Given this list of marker genes MAGT1, MIR29B1, SCN7A, ATP5MF (ATP synthase membrane subunit f), CATSPER4, PKD2, SPHK2, KCNH4, SLC39A8, FXYD5, PLCE1, PML, DIAPH1, CX3CL1, NDUFB10, ATP6V0E2, ASIC1, TMSB4X, KCNA7 (NCBI Gene Id 3743), TMEM63A, NDUFA7, FXYD3, GRINA, ATP5MGL, KCNG1, ATP13A4, CACNA1H, AKAP6, KCNJ4, WNK2, ATP4A, SLC25A14, UNC80, CALM2, CTNS (cystinosin, lysosomal cystine transporter), ATP1B1, PKD1L1, REM1, LETM1, ATP6V0C (NCBI Gene Id 527), ANO1, CXCR3, SLC17A8, SLC12A8, SLC25A25, MIR208B, TRPV4, CALCA, GSTO1, MT-ND5, SLC1A3, SLC5A2 (solute carrier family 5 member 2), LCN2, KCNJ3, NDUFB9, KCNMB1, NALF1, KCNH8, MCUR1, TRPM5 (transient receptor potential cation channel subfamily M member 5), PKD1L3 (polycystin 1 like 3, transient receptor potential channel interacting), PRKCE, SLC9A9, PTPRC, TTYH1 (NCBI Gene Id 57348), NIPSNAP2, KCNN2, SLC39A5, TRPM2, GPR35, SLC39A14, SLC5A9, SLC25A27, ATP5MG, HTR2C, UTRN, IFNG, SESTD1, CAV1, KCNE2, KCND2, WNK1, SLC25A5, SLC25A37, SLC38A4, SLC25A13, KCNA1, KCNN1, ANK2, ASIC5, NEDD4, GRIA2, CRHR1, CXCL10, MIR93, NDUFS7, P2RX3, KCNH5, CACNG6, BPIFA1, KCNAB3, SLC2A9, KCNK5, RYR1 (ryanodine receptor 1), PPP3CC, SLC18A1, SLC24A5, SLC22A1, CLIC2, ITPR2, NPSR1, CAB39, CHD7, ATP2B1, GAS6, SLC6A13, ATP6V1A, DRD1, CXCL9, UCP3, CACNA2D4, BEST2, ASPH, MT-ND4L, CACNG2, ROMO1 (NCBI Gene Id 140823), SCN5A, KCNH2, ATP6V1D, PLCB4, CCR7, KCND1, KCNG2, P2RX6, COX5B, TLR9, CXCL11 (NCBI Gene Id 6373), ATP2B2, CBLIF, CACNA1S, KCNJ1, NDUFA8, SLC5A1, HCN2, CHRNE, TRPM1, KCNJ10, TMEM163, SLC12A3, PLCH1, BIN1, ASIC3, TMBIM4, SLC30A6, COX5A, KCNQ3, SCN3A, FKBP1B, MCU, NDUFA9, TRPC6, MT-CO1, F2, ATP5PB, EDN1, TCN2, DRD2, TOR2A, HAP1, PPP3CA, ATP6V1G2 (ATPase H+ transporting V1 subunit G2), SLMAP (sarcolemma associated protein), JPH4, NDUFC2, TMC2, OTOP3, MIR212, SLC9A6, DLG1, GNB5, SLC39A3, SHROOM2, CNNM2, NDUFS3, KCNAB2, SLC6A2, SLC20A2, SLC25A23, SLC34A2 (NCBI Gene Id 153010), CACNA1D, NDUFV2, CAPN3, TMCO3 (transmembrane and coiled-coil domains 3), SLC41A2 (NCBI Gene Id 84102), JPH3, ABL1, SLC12A1, NDUFS8, ATOX1, NPPA, SLC17A7, MIR499A, TRPC3, DHRS7C, ATP5F1E, NIPAL3, ATP6V1F, ATP13A1, KCNG4, NDUFB5, STIM2, SLC6A5, KCNE3, ATG5, TRPV6, CASQ1, SCNN1D, RANGRF (NCBI Gene Id 51536), LYN, KCNJ15, BAK1, STAC, MIR328 (NCBI Gene Id 442901), PLCB1, ITGB3, CAV3, NOL3, ABCC5, NDUFB7, TMEM63B, ATP5PF, CLDN16, ATP6V0D2, SNCA, KCNA4 (potassium voltage-gated channel subfamily A member 4), KCNA2, SLC5A5, CACNA2D3, SLC9A7, KCNIP1, YWHAE, SLC12A7, ITPR3, OPRM1, SLC6A15, KCNS3, COX4I1, HSPA9, GRIN2B, ATP1A4, NDUFB1, APLNR, SCN4B (sodium voltage-gated channel beta subunit 4), SLC20A1, CORO1A, NCS1, NDUFB2, ATP5MC1, TMBIM6, GRIN3A, SLC39A1, PTPN6, P2RX7, SLC15A1, F2RL3, SLC39A2, ADCYAP1R1, ATP6V0D1, GRIN2D, KCNA10, ATP13A3, CATSPER2, CACNB2, PLCB3, GRIN2A, CCL21, NALF2, EDNRA, NDUFV1, ACTN4, SLC24A4, KCNE4, PRKACA, MCOLN2, PDE4D, MAIP1 (NCBI Gene Id 79568), COX7B, MIR1-1, ATP1B3, KCNU1, UBR3, MT-ND4, FHL1, CALHM2, KCNT2, KCNJ5, LRRC26, PTPN3, FGF12, SLC15A3, CACNA1B, MIR26A1 (microRNA 26a-1), SLC5A6, CEMIP, ASIC4, KCNK3, ATP5F1EP2, EPO (erythropoietin), SLC1A1, KCND3, CBARP, TPCN2, MIR133A1, KCNJ12, CCR5, SLC8A2, SLC39A12, CNNM4, KCNK12, SLC5A3, LRRC55 (NCBI Gene Id 219527), STRIT1, AFG3L2, PIEZO2, CHRNA7, UQCRC1, CACNG1, TMEM63C, SLC13A2, CACNA1E, DPP10, CD63, PKD2L2, MICU2, MMP9, CACNA1I, SLC24A3, SLC46A3, SLC9A4, JPH1, ATP2A3, CACNG3, SLC17A6, ABCB6, SLC25A18, KCNK13, CNGA4, CACNG5, ATP7A, GRXCR1, CATSPER3, SLC4A7, MT-ND2, NDUFA2, ATP6AP1, KCNH3, SLC36A3, IBTK, GALR2 (NCBI Gene Id 8811), CNGB3, SRI, SLC17A3, GPER1, SLC12A5, KCNN3, TRPC5, PSEN2, SLC6A14, HRC, KCNC3, PRNP, FAIM2, STING1, SELENON, ZACN, MIR24-1, HAMP, TSPAN13, NDUFA12, HCN4, NNT, SLC12A4, CALHM6, VDAC1, PKDREJ, ACTN2, UBASH3B, DMAC2L, CHERP, SCNN1G, CCL3, LRRC38, KCNMB2, MRS2, SLC8B1 (NCBI Gene Id 80024), NDUFA4, FGF2 (NCBI Gene Id 2247), CALHM4, SLC6A8, KCNK2, CALHM5, ATP6V0A4, OXSR1, CD4, SLC6A20, CNGA2, SCN9A, COX6B1, SLC41A3, ATP2C1, TRPV2, PLCG1, ATP4B, KCNH1, PLA2G1B, SLC40A1, SLC30A2, LCK, EDNRB, VMP1 (vacuole membrane protein 1), TESC, CACNG7, RNASEK, SLC25A28, SCN10A, SLC24A2 (solute carrier family 24 member 2), KCNJ13, PPP3R2, NDUFS4, ATP2C2, ATP6V0A2, CYBA (NCBI Gene Id 1535), HVCN1, TMEM150C, ABCC8, ATP6V1E2, GPM6A, UCP1, SMDT1, SLC39A7 (NCBI Gene Id 7922), SLC9A2, ITGAV (integrin subunit alpha V), SLC13A5, KCNF1, CATSPER1, ATP5PD, SLC30A1, CALM1, TMEM165, G6PD, SLC11A1, SLC13A4, SLC36A1, KCNC4, NTSR1, APP, CACNA2D2, MT-ATP6, WWP2, OTOP2, GRIN2C, CHRNA10, GRP, SCNN1B, SLC17A1, NDUFA5, P2RY6, SLC25A22, KCNJ16, GP1BB, SLC25A12, MT-ND6, CALHM3, PLCB2, TGFB1, CYC1, SLC9B1, UBQLN1, UQCRH, ATPSCKMT, ANO6, ATP12A, PTK2B, FGF13, TUSC3, ATP1A1, SCN2B, HTR2A, SLC17A4, LETM2, SCN1B, TMEM109, SLC30A7, SLC41A1, NIPAL4, TPCN1, SLC6A11, CACNB3, ATP13A2, ATP1B2, SLC30A4, SLC13A1, ATP5MC3, AKAP7 (NCBI Gene Id 9465), LRRC52, HPN, KCNIP3, BAX, CLCN7, ISCU, PLCL1, ORAI2 (NCBI Gene Id 84917), NIPA1, SLC36A2, AKAP5, AHNAK, KCNK1, ERO1A, PKD1, PLCL2, NDUFA1, ATP13A5, KCNG3, CD19, RGS4, DMD, SCNN1A, NOS1, KCNS1, TMEM38B, PCSK9, GHITM, SLC23A1, KCNC2, KCNK7, SCN3B, SLC9C1, KCNK10, SLC30A5, GRIN1, VAMP2, KCNN4, OTOP1, SEC61A1, KCNK17, FMR1 (NCBI Gene Id 5421), SLC38A2, HTT, SLC9A8, SLC6A17, TMEM94, UCP2, ZDHHC13, FASLG, HPCA, NDUFB3, CLCN3, SLC9B1P1, MT-CO3, UQCR10, TMCO1, SLN, SLC6A1, FXYD4, MT-ND1, NIPAL2, TCN1, SLC6A19, KCNB1, KCNK16, SURF1, COX8A (NCBI Gene Id 1351), PANX3, SLC24A1, PPP3R1, JPH2, SLC38A1, SLC29A4, ATP5MC2, GP5, NDUFC1, NDUFA3, NDUFS5, PDE4B, ATP1A3, KCNC1 (potassium voltage-gated channel subfamily C member 1), CACHD1 (NCBI Gene Id 57685), SLC39A9 (solute carrier family 39 member 9), MT-ND3, CACNA1A, ATP2A1, PHB2, STAC2, CACNA1F, ASIC2, SLC15A4, SLC30A9, SLC6A4, ORAI3, SLC32A1, TRPC4, GNB2, CHRNA9, MCOLN3, TRPM4 (NCBI Gene Id 8184), RYR2, MICU3, MCUB, NALCN, GP9, CALM3, GRM6, METTL21C, MMGT1, SLC6A12, XCR1, SLC6A16 (NCBI Gene Id 95514), MIR30D, ATP6V0A1, COX17, THY1, BDKRB1 (bradykinin receptor B1), PKD1L2, NIPA2 (NCBI Gene Id 96367), ATP5F1B, SLC17A5, NDUFB4, CNGA3, GAL, TMEM175, ITPR1, SCN8A, SLC2A10, SCN4A, SLC25A3, CACNA2D1, IL13, MIR103A1, STIMATE, MIR21, FXYD6, KCNE5, PSEN1 (presenilin 1), TRPV5, SLC18A2, CNGB1 (NCBI Gene Id 1258), ATP5PO, KCNA6 (NCBI Gene Id 3742), ATP2B4, TCIRG1, BHLHA15, PIEZO1, SLC46A1, SLC18A3, SLC12A2, SLC39A4, CCT8L2, CCL19, NOS1AP, ATP5ME, ATP6V1B1, CASQ2, STAC3, SLC30A8, TRPV1, ATP6V1G1, SCN1A, PRKD1, FXYD7, NDUFV3, WNT3A, KEL, KCNJ6, COX7A1, CTSS, SLC39A6, ATP5F1C, KCNIP2 (NCBI Gene Id 30819), MTCO2P12, SLC12A6, CACNA1C, XCL1, KCNS2, KCNJ11, SLC31A1, TRPC7, SCN11A, FXYD1, CALHM1, ATP6V1C2, SLC16A1, SUMO1, KCNA5, NDUFB8, P2RX1, NDUFS2, KCNB2, ABCB7, P2RX2, ANK3, ATP7B, CHP1, TMEM37 (transmembrane protein 37), SLC31A2, MIR208A, SLC34A3 (solute carrier family 34 member 3), PLCG2, STIM1, KCNMB3, RGS9, KCNQ4 (potassium voltage-gated channel subfamily Q member 4), KCNAB1, TRPM8, GSTM2, FXYD2, PANX1, ATP2A2, TRPC1, SLC25A4, NIPAL1, SLC4A10, KCNJ18 (NCBI Gene Id 100134444), ATP6V1G3, SLC8A1, KCNK9, ATP2B3, ANO9, PIK3CG, SLC39A11, PMPCB, NOX5, NEDD4L, WNK3, ATP6V0B, KCNH6, AMIGO1, EDN3, KCNV1, SLC13A3 (NCBI Gene Id 64849), SLC5A11, SNTA1, TRPV3, CNGA1, MS4A1, UQCRFS1P1, CAMK2D (NCBI Gene Id 817), STEAP2, SLC6A3, FXYD6P3, TRPC4AP, SLC47A1, MIR448, CACNG4, GRIN3B, SLC9A1 (NCBI Gene Id 6548), KCNIP4, SLC39A13, KCNJ14, KCNK15, KCNK4, ABCC9, LIME1, SLC6A9, CACNB1, SLC38A5, COX7A2L, ATP8A1, SLC17A2, KCNV2, FKBP1A, ATP6V1E1, SLC34A1, HEPH, TMEM38A, ATP1A2, SLC9A5, CACNG8, TRPM3, AGT, SLC4A5, CUL5, FYN, SLC35G1, SLC9C2, ATP6V1C1, SLC5A10, SLC12A9, UQCRFS1, NDUFB6, OPRK1 (opioid receptor kappa 1), SPG7, F2R, CACNB4, ATP6V1B2, SLC30A3, RYR3, ATP6AP2, SLC39A10, KCNJ8, SLC9A3, SLC11A2, KCNT1, SLC6A6, DDIT3, NDUFS6, KCNMB4, WNK4, MT-ATP8, NGF, AP3D1, ATP6V0E1, STK39, HCN3 (NCBI Gene Id 57657), KCNQ2, DPP6, MIR192, KCNE1, ATP5F1D, SLC28A3, KCNMA1, NDUFA6, KCNA3, KCNK18, AQP1, GP1BA, PLN, PKD2L1, KCNH7, SLC6A7, TRDN, CRACR2A, HCN1, MT-CO2, KCNQ5, SCARA5, SNAP25, KCNJ9, TMBIM1, KCNK6, BCL2, PDPK1, SLC30A10, TRPM6, TRPM7, MIR210, ATP6V1H, LACRT, HTR2B, COMMD1, MCOLN1, SLC15A2, TMC1, SLC6A18, SLC18B1, SLC9B2, KCNJ2, LARGE1, SCN2A, P2RX5, NDUFS1, CACNA1G, MIR200C, ORAI1, P2RX4, CCDC51, OSR1, ATP5F1A, PPIF, SLC4A8, NDUFA10, MICU1 (NCBI Gene Id 51415), KCNRG, SLC4A9, PPP3CB, SLC4A4, ANO10, SLC8A3, SLC5A4, PLCH2, ABCB8, MT-CYB, KCNQ1, TRPA1, SLC48A1, SLC4A11 (solute carrier family 4 member 11), SLC47A2, FLNA, here is a description of the gene set: The process in which a monoatomic cation is transported across a membrane. Monatomic cations (also called simple cations) are positively charged ions consisting of exactly one atom. species: Homo sapiens Human Gene Set: GOBP_MONOATOMIC_CATION_TRANSMEMBRANE_TRANSPORT